Given this list of marker genes CLDN4, SLC6A15, SMPD3, CYP39A1 (cytochrome P450 family 39 subfamily A member 1), ANKRD6, CIAO2A, ATP8A1, TLE1, DSCAM, MOGAT3, UNC5C, SLAIN2, PABIR2, GPD2, TMSB15B, PDCD4, EFCAB2, ANKRD27, EGFR, TVP23C, COL12A1, RAB21, PLS1, DOCK5 (NCBI Gene Id 80005), RIC8B, DNAJB7, SNRPA1, DDX21, L2HGDH, CROT (carnitine O-octanoyltransferase), GABRR1, MYOM1, RP1L1, PGM2, DENND2C, PRICKLE2, IGFBP7, LYPLA1, MAP7, EPOR, CD164, VAPA, LGALSL (galectin like), EPHA5, SLC30A7, SOCS4, NR1D2, ZNF99, CDC37L1, BEND6, TRAF3, CCDC125, PYROXD1, ITCH, NIT1, RD3L, ANKRD7, ZNF138, SLC22A2, BRWD3, RNF212, TVP23B, RFTN2, SHE, ALG10 (ALG10 alpha-1,2-glucosyltransferase), GIT2, CTNNA2, DNAJC15, HTR2C, ZNF239, TM4SF4, PCYOX1L, HNRNPR, CYTIP, NEGR1, POGZ, ZCCHC14, ETNK1, SPPL2A, RAPGEF4, SEMA5A (semaphorin 5A), PDXDC1, TCHP (trichoplein keratin filament binding), VWA8, IKZF5, MIER3, SCAMP1, ZNF626, NUP155, DACH1, CTTNBP2, IL1RAP, BTN3A1, NIF3L1, RB1, TNFAIP6, SMARCC1 (SWI/SNF related, matrix associated, actin dependent regulator of chromatin subfamily c member 1), LCOR, ABCC9, COL19A1, TDRD15, SH3YL1, CRIM1, MAP10, NOL4, DNAJC3, COL6A6, FSHB, SH3BP4, NLRP1, FBXL17, ELMOD2, SLC12A1, ZNF829, TRIM5, FMNL2, SYF2, KIF2A, PDE1A, FMN1, GABARAP, TRMT11, FAM174A, PARM1, ZNF512B, ABHD12B (abhydrolase domain containing 12B), MTMR9, ZNF333, here is a description of the gene set: Human Gene Set: MIR3674 Genes predicted to be targets of miRBase v22 microRNA hsa-miR-3674 in miRDB v6.0 with MirTarget v4 prediction scores > 80 (high confidence targets). species: Homo sapiens from publication Chen Y, Wang X (PMID 31504780)